Given this list of marker genes Usp32, Dcun1d3, Sox6, Wfikkn2, Cachd1, Nampt, Arhgap6, Igf2, Arl8b, Cep170, Naaladl2, Atf7ip2, Tjap1, Actl6a, Dock5, Ppp1r26, Snap25, Pak3, Myom2, Ralgapb, Kcnj1, Wdcp, Abcc1, Spns2, Plekhb1, Brwd1, Papss1, Prr13, Tmem267, Gabra1, Plp1, Rin1 (Ras and Rab interactor 1), Syn2, Ppp1r1c, here is a description of the gene set: Genes predicted to be targets of miRBase v22 microRNA mmu_miR_7689_3p in miRDB v6.0 with MirTarget v4 prediction scores > 80 (high confidence targets). from publication Chen Y, Wang X (PMID 31504780) species: Mus musculus Mouse Gene Set: MIR_7689_3P